The following is a description of a gene set: studied in species Homo sapiens Binding to a heparan sulfate proteoglycan, any proteoglycan containing heparan sulfate as the glycosaminoglycan carbohydrate unit. Human Gene Set: GOMF_HEPARAN_SULFATE_PROTEOGLYCAN_BINDING, and this is the list of marker genes: LRP1, SEMA5A, FGF20, PTPRC, FST, SLIT1, COMP, HPSE2, FBLN7, APOE, PLA2G2D, CFH, PTPRS, APP, LPL, ITGA2 (integrin subunit alpha 2), AZU1, AGRN, HRG